The following is a description of a gene set: electronically inferred by orthology from the curated human pathway species: Mus musculus part of: Metabolism of RNA This event has been computationally inferred from an event that has been demonstrated in another species.<p>The inference is based on the homology mapping from PANTHER. Briefly, reactions for which all involved PhysicalEntities (in input, output and catalyst) have a mapped orthologue/paralogue (for complexes at least 75% of components must have a mapping) are inferred to the other species. Reactome Pathway: Nonsense-Mediated Decay (NMD), and this is the list of marker genes: Rps19 (NCBI Gene Id 20085), Rps4x, Rps7, Rpl4, Rps3a1, Ppp2r2a, Rpl9, Smg7, Rpl39, Rpl38, Rpl3l, Rpl23a, Rps2, Rps15, Rpl36a, Rpl13, Rpl39l, Rps8, Rpl36al, Rpl6, Rpl37, Rps9, Rpl14 (NCBI Gene Id 67115), Magoh, Rps24, Rps5, Rpl29, Rps18, Rps28 (ribosomal protein S28), Upf2, Rps6 (ribosomal protein S6), Rpl37a, Gspt2 (G1 to S phase transition 2), Fau, Rps17, Ubb, Rpl7, Rplp2, Rps11, Smg8, Rnps1, Rps25, Rps27l, Rpl27, Rpl11, Rpl12, Rpl26, Rpl37rt, Magohb, Rps12, Rps26, Rps23, Pabpc1, Rpl3, Rpl19, Rpl15, Rpl27a, Rps13, Rpl18a, Rpl24, Rps10, Casc3, Upf3b, Rpl18, Rps20, Dcp1a